Given this list of marker genes GRK1, NMT2, GUCY2D, RP1, CAMKMT, GNAT3, PCP2, GRK7, GUCY2F, GRK4, GNAQ, PDE6C, AIPL1, GNAT1, RHO, NMT1, TTR, PDE6B, PNPLA2, SAG (NCBI Gene Id 6295), RBP4 (retinol binding protein 4), ABCA4, GNA11 (G protein subunit alpha 11), here is a description of the gene set: The sequence of reactions within a cell required to convert absorbed photons from visible light into a molecular signal. A visible light stimulus is electromagnetic radiation that can be perceived visually by an organism; for organisms lacking a visual system, this can be defined as light with a wavelength within the range 380 to 780 nm. species: Homo sapiens Human Gene Set: GOBP_PHOTOTRANSDUCTION_VISIBLE_LIGHT